The following is a description of a gene set: Human Gene Set: GOBP_RNA_EXPORT_FROM_NUCLEUS The directed movement of RNA from the nucleus to the cytoplasm. species: Homo sapiens, and this is the list of marker genes: NCBP3, NRDE2, THOC6, HHEX, FMR1, SEM1, UPF1, PABPN1, POLDIP3, THOC3, PHAX, THOC7, NXT1, THOC2, MAGOH, YTHDC1, NXF2, DHX9, ALYREF, NUP153, ENY2, NUP160, IWS1, XPO5 (exportin 5), EIF4A3, RBM8A, NOL6, SSB, POM121C, GLE1, ZC3H11A, NUP188 (NCBI Gene Id 23511), SETD2, NXF2B, THOC5, RBM15B, HNRNPA2B1, NXF1, THOC1, DDX39A, POM121B, NXF5, KHDRBS1, SMG6 (NCBI Gene Id 80091), PCID2 (NCBI Gene Id 55795), EIF4E, NPAP1, FYTTD1, RAN, UPF2, NUP155, SARNP, NUP85, NUP62, NUP107, SMG5, NUP98, MAGOHB, CHTOP, DDX25, NCBP1, ALKBH5, RBM33, ZC3H11C, NUP88, SRSF3, NXF3, NUP93, NUP214, DDX19B, C12orf50, SMG1, TPR, MCM3AP, DDX19A, DDX39B, AGFG1, SMG7, RAE1, XPO1, XPOT, CASC3, ZC3H11B, NCBP2, NEAT1, NUP133 (NCBI Gene Id 55746), HNRNPA1, NXT2, WNK1, POM121L2, POM121, AKAP8L, CPSF6 (NCBI Gene Id 11052), NSUN2